Given this list of marker genes FGFR2, FGF20, FGF6, FGF8, PLCG1, FGF2, FGF16, FGF22, FGF9, FGF10, FGF1, FGF17, FGF4, FGF3, FGF5, FGF7, FGF23 (NCBI Gene Id 8074), FGF18, here is a description of the gene set: species: Homo sapiens Reactome Pathway: Phospholipase C-mediated cascade; FGFR2 part of: Downstream signaling of activated FGFR2 Phospholipase C-gamma (PLC-gamma) is a substrate of the fibroblast growth factor receptor (FGFR) and other receptors with tyrosine kinase activity. It is known that the src homology region 2 (SH2 domain) of PLC-gamma and of other signaling molecules (such as GTPase-activating protein and phosphatidylinositol 3-kinase-associated p85) direct their binding toward autophosphorylated tyrosine residues of the FGFR. Recruitment of PLC-gamma results in its phosphorylation and activation by the receptor. Activated PLC-gamma hydrolyzes phosphatidyl inositol P2 to form the second messengers diacylglycerol (DAG) and InsP3, which stimulate calcium release and activation of calcium/calmodulin dependent kinases.<br>